Given this list of marker genes CDC42, BRD4, ANKRD11, EFTUD2, B3GLCT, FGFR2, HEATR3, SLC26A2, KCNH1, BAP1, SHMT2, RRAS2, BMP4, ZNF462, NKX3-2, TAF6, ALG9, LONP1, GATA4, NIPBL, PTRH2, RAD51C, TP63, RAD21, CTCF, CNOT1, SIN3A, ZIC3, SMC1A, MEGF8, BPNT2, HOXA13 (NCBI Gene Id 3209), HDAC8 (histone deacetylase 8), ERI1, DHCR7, RECQL, SMC3, FLNA, ZC4H2, FRA10AC1, CRIPT, FLNB, CHSY1, NOG (noggin), WDR26, TFAP2A, TBX5, MGAT2, FANCB, ALG12, ESCO2, CILK1, BRCA1, EIF4A3, here is a description of the gene set: species: Homo sapiens Human Gene Set: HP_DEVIATION_OF_THE_THUMB Deviation of the thumb Displacement of the thumb from its normal position.